The following is a description of a gene set: species: Homo sapiens Human Gene Set: MIR517A_3P_MIR517B_3P_MIR517C_3P from publication Chen Y, Wang X (PMID 31504780) Genes predicted to be targets of miRBase v22 microRNA hsa-miR-517a-3p, hsa-miR-517b-3p, hsa-miR-517c-3p in miRDB v6.0 with MirTarget v4 prediction scores > 80 (high confidence targets)., and this is the list of marker genes: DGKH, CCDC89 (coiled-coil domain containing 89), ZNF521, CLIC4, NFIA, TMCC1 (NCBI Gene Id 23023), HERPUD2, PHF13, CBLN2, VSTM2B, PTK2B, FOXJ3, NFIC, SHANK1, DBN1, TNIP1, NFIB, SMIM14, HOXA5